The following is a description of a gene set: species: Mus musculus Mouse Gene Set: WP_LUNG_FIBROSIS Lung fibrosis, and this is the list of marker genes: Skil, Pdgfa, Ptx3, Calca, Hmox1, Il4, Elmod2, Dsp, Stn1, Hgf, Fgf2, Nfe2l2, Muc5b, Edn1, Plau, Egf, Pdgfb, Sftpc, Fam13a, Igf1, Ccl2, Il1b, Il13, Atp11a, Il12b, Rtel1, Csf2, Mecp2, Mmp2, Ccl4, Bmp7, Fgf7, Ccr3, Ccl5, Ccl11, Tert, Sftpa1, Mt2, Mmp9, Cxcl2, Cebpb, Cysltr2, Tgfb1, Il6, Cma1, Ccn2, Timp1, Spp1, Eln, Cxcl15 (C-X-C motif chemokine ligand 15), Tnf, Smad7, Dpp9, Fgf1, Parn, Csf3, Il5, Tgfa (NCBI Gene Id 21802), Ccr2, Ccl3